Given this list of marker genes RAP1GDS1, TRAK2, MYO19, TRAK1, RHOT1, here is a description of the gene set: RHOT1 GTPase cycle Human Gene Set: REACTOME_RHOT1_GTPASE_CYCLE species: Homo sapiens